The following is a description of a gene set: Mouse Gene Set: REACTOME_CASPASE_ACTIVATION_VIA_DEATH_RECEPTORS_IN_THE_PRESENCE_OF_LIGAND studied in species Mus musculus Caspase activation via Death Receptors in the presence of ligand, and this is the list of marker genes: Ly96, Tlr4, Casp8 (caspase 8), Ticam2, Cd14, Fasl, Fas, Ripk1, Tradd, Cflar, Tnfsf10, Ticam1, Fadd, Traf2, Tnfrsf10b